Given this list of marker genes ENPP1, DHX9, DCTPP1, ENPP3, ASMTL, NUDT1, ITPA, NUDT16, NUDT15, DUT, here is a description of the gene set: Catalysis of the reaction: a nucleoside triphosphate + H2O = a nucleotide + H+ + diphosphate. studied in species Homo sapiens Human Gene Set: GOMF_NUCLEOSIDE_TRIPHOSPHATE_DIPHOSPHATASE_ACTIVITY